Given this list of marker genes WIPF1, EPB41L3, ANK2, SPTBN4, GAS2L1, JUP, INSC, BICD1, GAS2L2, SDCBP, MAP1A, MARK4, ABI2, ANK3, BIN3, NCK1, NCK2, BICD2 (BICD cargo adaptor 2), SYN1, ANK1, BAIAP2, MICALL1, SORBS2, OBSL1, here is a description of the gene set: The binding activity of a protein that brings together a cytoskeletal protein (either a microtubule or actin filament, spindle pole body, or protein directly bound to them) and one or more other molecules, permitting them to function in a coordinated way. Human Gene Set: GOMF_CYTOSKELETAL_ANCHOR_ACTIVITY studied in species Homo sapiens